Given this list of marker genes BANF1, PRXL2B, ZCCHC17, LAMTOR3 (late endosomal/lysosomal adaptor, MAPK and MTOR activator 3), MICOS13, ACSL4, SLC7A11, PBK, PGAM2, STK17B, PDHA1, LIPT2, ABCG2, SGO1, STARD4, SNF8, SMAD2, LAMB1, LPCAT1, AKAP8, ARCN1, ABCD2, SLC4A8, NDC1, RRP9, TOPBP1, TLR1, TMEM263, TFEB, ABCB4, ATP2A2, ABRACL, SMIM11, RBMXL1, UBE2J1, DNAJB11, TREM1, DYNC1I2, HDAC1, SLC22A25, LRP6, STARD7, GORASP1, RHOC, ITCH, SMN1, CAMK1D, MORF4L1, CSE1L, SLC44A1, PRXL2A, ITSN1, SLC25A39, EIF4B, MCM7, HLX, SBK1, QNG1, IL18, FNTA, TMEM51, CRYBG3, ARHGAP21, NADK, GPR84, WDFY3, ATP13A3 (ATPase 13A3), CCDC80, SSBP3, MRPS2, SLC41A2, ADRA2A, PLD1, FASN, SSBP4, TMEM38B, F11R, PHTF2, FCER1G, THRSP, TM9SF3, LPCAT3, ATG7, EDN3, AIF1, MAGOHB, PALD1, SOCS1, PLP2, RIOX2, ACVR1B, SLC12A4, SMC2, TFF2, GNA15, NFAM1 (NFAT activating protein with ITAM motif 1), ADAM9, SNX4, NUCKS1, MAT2A, OPN3, API5, NUP93, HACD3, UTP11, ANXA1, SOX4, RCOR1, MRPL52, FGD3, FAM13B, SLC13A3, C8orf76, FARSB, ARHGAP24, RGS18, DHPS, GPR155, SH2B3, STT3A, PSEN1, CLMN, HSPA5, FDPS, SMYD5, SRM, ATP1A3, SPC25, MGAT2, SEPHS2, ESYT3, TXNIP, SMC3, PSMA6 (proteasome 20S subunit alpha 6), LSS, P2RY6, LIMD1 (LIM domain containing 1), COL5A1, LTN1, MADD (NCBI Gene Id 8567), EREG, PANK3, FTH1, CXCL3, UNC119, GNG2, KREMEN1, RNF128, SLC4A4, MSANTD3, MRPS28, IGHM, DHCR7, LAIR1, MRC1, B3GNT2, CDK1, TPST2, S100A1, MKNK1, SCFD1, S100A8, CP, CMTM3, KPNA2, EPS15, GADD45A, CCT6A, MAG, METRNL, EEF2K, NOP16, KLHL7, TNIP1, SELENOT, SMC1A, BNIP2, RRAS, DGAT2, NSDHL, GPSM2, STAMBPL1, SVIL (NCBI Gene Id 6840), PICALM, MARCHF6, ATP5PO, SREBF2, TXNDC5, STARD8, ARHGAP18, UBQLN1, YWHAB, TNFRSF21, PPP1R21, HPRT1, SYT11, CASD1, NSG1, HDHD5, TRIM60, here is a description of the gene set: Human Gene Set: GSE17721_LPS_VS_GARDIQUIMOD_24H_BMDC_DN Genes down-regulated in comparison of dendritic cells (DC) stimulated with LPS (TLR4 agonist) at 24 h versus DC cells stimulated with Gardiquimod (TLR7 agonist) at 24 h. from publication Amit I, Garber M, Chevrier N, Leite AP, Donner Y, Eisenhaure T, Guttman M, Grenier JK, Li W, Zuk O, Schubert LA, Birditt B, Shay T, Goren A, Zhang X, Smith Z, Deering R, McDonald RC, Cabili M, Bernstein BE, Rinn JL, Meissner A, Root DE, Hacohen N, Regev A (PMID 19729616) species: Homo sapiens mouse primary BMDCs were stimulated with tlr ligands and gene expression changes were profiled on Affymetrix arrays